The following is a description of a gene set: studied in species Homo sapiens We previously identified toll-like receptor 4 (Tlr4) as a candidate gene responsible for ozone (O3)-induced pulmonary hyperpermeability and inflammation. The objective of this study was to determine the mechanism through which TLR4 modulates O3-induced pulmonary responses and to utilize transcriptomics to determine TLR4 effector molecules. C3H/HeJ (HeJ; Tlr4 mutant) and C3H/HeOuJ (OuJ; Tlr4 normal), mice were exposed continuously to 0.3 ppm O3 or filtered air for 6, 24, 48 or 72 hr. Affymetrix Mouse430A_MOE gene arrays were used to analyze lung homogenates from HeJ and OuJ mice followed using a bioinformatic analysis. Inflammation was assessed by bronchoalveolar lavage and molecular analysis by ELISA, immunoblotting, and transcription factor activity. TLR4 signals through both the MYD88-dependent and independent pathways in OuJ mice, which involves MAP kinase activation, NF-kappaB, AP-1, and KC. Microarray analyses identifiedTLR4 responsive genes for strain and time in OuJ versus HeJ mice (p<0.05). One significantly upregulated cluster of genes in OuJ were the heat shock proteins (Hspa1b; Hsp70), Hsp90ab1). Furthermore, O3-induced expression of HSP70 protein was increased in OuJ compared to HeJ mice following 24-48 h O3. Moreover, BAL polymorphonuclear leukocytes (PMN) and total protein were significantly reduced in response to O3 in Hspa1a/Hspa1btm1Dix (Hsp70-/-) compared to Hsp70+/+ mice (p<0.05). TLR4 signaling (MYD88-dependent), ERK1/2, AP-1 activity, and KC protein content were also significantly reduced after O3 exposure in Hsp70-/- compared to Hsp70+/+ mice (p<0.05). These studies suggest that HSP70 is involved in the regulation of O3-induced lung inflammation through the TLR4 pathway and provide evidence that HSP70 is an endogenous in vivo TLR4 ligand. Human Gene Set: GSE20715_0H_VS_48H_OZONE_TLR4_KO_LUNG_DN Genes down-regulated in comparison of lung tissue from wild type mice subjected to ozone for 0 h versus that from TLR4 deficient mice subjected to ozone for 48 h. from publication Bauer AK, Rondini EA, Hummel KA, Degraff LM, Walker C, Jedlicka AE, Kleeberger SR (PMID 21543283), and this is the list of marker genes: GADD45G, SLC5A1, VPS37C, MSMO1 (NCBI Gene Id 6307), MDN1, PSMD2, GJA1, TMEM132A, MRPL12, PMEPA1, DDX39A, CISH, STAM, EEF1E1, CTSH, HOMER2, LDHA, CKS2, S100A6, FOXN2, KPNA2, EMG1, MCFD2, ITGA9, RAB2A, ERLIN1, COX5A (cytochrome c oxidase subunit 5A), HSP90B1, ST13, CNIH1, RPL18, F3, CACYBP, ALDH3A1, LRG1, RANBP1, DNAJB1, CCT7, COX16, SFPQ, ADM, AREG, OSMR, PHLDA1, ERH, TMEM176A, REX1BD, LSM2, TFEC, UCHL3, TXNDC11, APC, CKAP4, NPC2, TRIM3, LBP, TMEM39A, MRPS18B, ACTN1, ISYNA1, HSPH1, KRT18, BPNT1, KRT8, FETUB, ELL2, GCNT3, LRRC59, NFIL3, HYOU1, SLC39A14, DIDO1, RHOU, SOCS3, CEP55, PGK1, EIF2S1, TXN2, CCNB2 (NCBI Gene Id 9133), AACS, PRPF38B, TTK, HEATR1, RAD51, MIF, EREG, SPCS3, BHLHE22, HNRNPLL, KDELR3, SPP1, ELF3, FOXK2, EIF3A, SERPINA3, NEDD1, EPCAM, PCNA (proliferating cell nuclear antigen), COX19, BUD23, PSMA2, CALR, SEC23A (NCBI Gene Id 353367), UAP1, MYC, MANF, DCTN3, IGF1, CKS1B, DPAGT1, LGALS3, RPP30, FDFT1, LTV1, METTL1, DMKN, MVD, PPA1 (inorganic pyrophosphatase 1), TRAF3, UHRF1, ESRP2, PBK, ALG2, RRAS2, UBE2G2, TRA2B, IDI1, PRSS22, CLU, CYP7B1, CIAPIN1, GPX2, ESD, SQLE, SSR1, STRAP, SRSF6, TFRC, TUFT1, PRPF31, SLC3A2, ELN, SMPD1, EIF6, KHDRBS3, CCL22, TNC, MIEN1, HNRNPAB, CD14, S100A14, GCLC, EPHA2, DNAJC21, COP1, PLP2, HSPA8, CXCL17, LDLR, NRCAM, PPP1R14B, VMP1, KCTD10, TUBB, PTPN1, CDK2AP2, LITAF, RIN1, BUB1, BYSL, YWHAG, CXCL2, SDF2L1 (stromal cell derived factor 2 like 1), IL33, YRDC, THBS1, PPRC1, KIF20A, CXCL6, TCEAL9, HSPD1, EIF4E, SYVN1, ACOT7, CDKN1A (NCBI Gene Id 1026), SKP1, HMGCS1, STK40, STAT3, RRM2, LCN2, SOD2, TK1, DNAJA1, HINT1, EEF1G, LRP2, CDK1, SLC20A1, AKR1B15